The following is a description of a gene set: Catalysis of the joining of two molecules via a carbon-sulfur bond, with the concomitant hydrolysis of the diphosphate bond in ATP or a similar triphosphate. Mouse Gene Set: GOMF_LIGASE_ACTIVITY_FORMING_CARBON_SULFUR_BONDS species: Mus musculus, and this is the list of marker genes: Slc27a4, Atg7, Mocs3, Uba2, Acsbg3, Aacs, Slc27a2, Acsf3, Acsbg1, Sae1, Acss2, Acsm3 (NCBI Gene Id 20216), Acsm4, Acsl3 (acyl-CoA synthetase long-chain family member 3), Acsf2, Slc27a5, Uba3, Acsl1, Uba6, Uba7, Acsl6, Slc27a3, Acsm1, Suclg2, Suclg1, Acsl5, Acsl4, Uba1, Nae1, Acsbg2, Slc27a1, Uba5, Aasdh, Acss3, Sucla2, Acsm2, Acss1, Slc27a6, Acsm5, Dip2a, Uba1y